Given this list of marker genes INPP5K, SIX4, MIER1, BRWD1, CALU, TMEM178B, ARMC8 (armadillo repeat containing 8), L3MBTL3, FOXO3, SEMA6A, ZNF652, SEC16A, VDAC2, PTBP2, ADAMTS5, FEM1C, KDM5A, RB1, SIPA1L2, DAZAP2, PBOV1, ZYG11A, SPATA13, TIMM9, G3BP2, LEMD3, TJAP1, ZBTB20, SIRT1, FRS2 (NCBI Gene Id 10818), MIS12, KCNK2, NFATC2, CACNB1, RGS7BP, MTMR10, KCNA6, ASF1A, PAM, MIDEAS, EP300, ENPP4, USP38, H2AZ1, TMEM64, SLC25A28, NLK, ALKAL1 (ALK and LTK ligand 1, NCBI Gene Id 389658), DPYSL3, CCDC71L, CHD1, USP9X, SGK3, PCDH10, EPB41L5, CCDC28A-AS1, PYURF, NOVA1, HHIP (hedgehog interacting protein), SOD2, GPATCH2L, ZNF521, SALL1, DAAM1, KLF7, CELSR3 (NCBI Gene Id 1951), NREP, PGM5, ZNF516, GRM3, SPRED1, ETNK1, FAM76B, LSM11, ZHX1, RICTOR, RPL31, GPD2, AMER2, FAM167A, WDR5B, CCN2, MED9, CLMN, DDX5, FAM91A1, DCUN1D4, TMEM164, E2F5, CDK19, NTNG1, LRRFIP1, MUC13, LIN28B, SLC6A1, SPPL3, OSBPL8, SCN3A, MTF2, RHOQ, CACNG2, PPM1G, TUT4, RAD54L2, SOX11, TRNAU1AP, NACC2, ZNF451, AMD1, NFE2L2, POM121, MYCBP2, KRTAP4-1, CD300LF, TLN2, SAP30L, ZBTB18, METTL25 (methyltransferase like 25), SLC26A7, STX16, DIPK2A, FBXO9, NMNAT2, TRDN (triadin), RASA1, KCNN3, SSH2, SOX5, PHF12, LRRC58 (NCBI Gene Id 116064), ARID1B, DYRK2, HNRNPH1, AEBP2, SKAP2, CBLL1, BRI3, GDF5, TLCD5, ZNG1C, BOLL, CC2D1B, RUFY3, CAMSAP2, MELK, HBEGF, SS18, MEF2A, ATP10D, COL11A1, ACVR2B, SETD5, CCDC88A, SALL4, AGO1, ADCY3, INAFM2 (InaF motif containing 2), NVL (nuclear VCP like), ARID2, MAPK1, AZIN1, CCDC34, FBXL20, C8orf44-SGK3, CNR1, HNRNPM, BRD10, KCMF1, RPP14, ATXN1, ZNG1A, SERP1, TSPAN6, CSDE1, SYN2, MEX3C, PSMD12, DCC, GMFB (glia maturation factor beta), SLC30A6, EFCAB9, SEPTIN8, GTF2H1, MIA3, SLC1A3 (NCBI Gene Id 6507), FAM227A, ZNG1B, DUSP9, STAG1, SRGAP1, here is a description of the gene set: from publication Chen Y, Wang X (PMID 31504780) Genes predicted to be targets of miRBase v22 microRNA hsa-miR-132-3p in miRDB v6.0 with MirTarget v4 prediction scores > 80 (high confidence targets). Human Gene Set: MIR132_3P studied in species Homo sapiens